The following is a description of a gene set: EGFR-overexpression to PI3K signaling pathway. Pathway ID: N00042. Pathway type: Variant. Pathway class: nt06260 Colorectal cancer. Human Gene Set: KEGG_MEDICUS_VARIANT_EGFR_OVEREXPRESSION_TO_PI3K_SIGNALING_PATHWAY Pathway Definition from KEGG: EGFR* -> PI3K -> PIP3 -> AKT -> MTOR -> S6K species: Homo sapiens, and this is the list of marker genes: AKT2, PIK3CB, AKT3, PIK3CD, EGFR, RPS6KB2, MTOR, RPS6KB1, PIK3CA, AKT1